Given this list of marker genes Bcl7a, Smarcb1, Pbrm1, Smarcc2, Smarcd1 (NCBI Gene Id 83797), Smarcd2, Ercc8, Smarce1, Phf10, Actb, Rad52, Actl6b, Arid2, Dpf1, Smarcc1, Dpf3 (NCBI Gene Id 97800), Kat7, Brd7, Bcl7c, Hmgb1, Dpf2, Smarcd3, Actl6a, Cul4a, Bcl7b, Smarca2 (NCBI Gene Id 67155), Smarca4, Arid1a, here is a description of the gene set: Any process that modulates the frequency, rate or extent of nucleotide-excision repair. Mouse Gene Set: GOBP_REGULATION_OF_NUCLEOTIDE_EXCISION_REPAIR studied in species Mus musculus